Given this list of marker genes DCUN1D1, STAT3, DR1, WDR41, SLC17A7, NKX2-2, NAA50, BCL2, DYNLL1, SP3, PRKAR2B, NUP43, HIPK1, CCDC88A, KIF18B (kinesin family member 18B), SYT10, PSME4, FAM50B, IL17RD, SPTBN1, MAP4K5, RAB2A, ACTR2, POM121, RHOBTB1, CAND1, ZNF441, OXLD1, DSCAML1, ST20-MTHFS, MAML3, B3GLCT, MTX3, PYGO1, GABRB2, BTBD10, GAN, MICAL3, PPCDC, GID4, BTBD1, FAM98A, LINC02694, RNF19A, ATP5MC3 (NCBI Gene Id 518), HMGN3, EPN3, PHF20L1, PLAA, ZMYM2, ZIC4, FBXO48, CUL4B, DDX3X, WIPI1, TRDN, ESYT3, CHMP2B, DIAPH3, YIPF5, NPY1R, MTHFS, WDFY3, here is a description of the gene set: Genes predicted to be targets of miRBase v22 microRNA hsa-miR-6776-3p in miRDB v6.0 with MirTarget v4 prediction scores > 80 (high confidence targets). Human Gene Set: MIR6776_3P studied in species Homo sapiens from publication Chen Y, Wang X (PMID 31504780)